The following is a description of a gene set: Any process that stops, prevents, or reduces the frequency, rate or extent of T-helper 2 cell differentiation. Human Gene Set: GOBP_NEGATIVE_REGULATION_OF_T_HELPER_2_CELL_DIFFERENTIATION studied in species Homo sapiens, and this is the list of marker genes: ASCL2, SOCS5, ANXA1, BCL6, HLX (NCBI Gene Id 3142)